The following is a description of a gene set: from publication Zhou Q, Brown J, Kanarek A, Rajagopal J, Melton DA (PMID 18754011) Transcription factors expressed in progenitors of endocrine pancreatic cells. Human Gene Set: ZHOU_PANCREATIC_ENDOCRINE_PROGENITOR studied in species Mus musculus One goal of regenerative medicine is to instructively convert adult cells into other cell types for tissue repair and regeneration. Although isolated examples of adult cell reprogramming are known, there is no general understanding of how to turn one cell type into another in a controlled manner. Here, using a strategy of re-expressing key developmental regulators in vivo, we identify a specific combination of three transcription factors (Ngn3 (also known as Neurog3) Pdx1 and Mafa) that reprograms differentiated pancreatic exocrine cells in adult mice into cells that closely resemble beta-cells. The induced beta-cells are indistinguishable from endogenous islet beta-cells in size, shape and ultrastructure. They express genes essential for beta-cell function and can ameliorate hyperglycaemia by remodelling local vasculature and secreting insulin. This study provides an example of cellular reprogramming using defined factors in an adult organ and suggests a general paradigm for directing cell reprogramming without reversion to a pluripotent stem cell state., and this is the list of marker genes: MYT1, NEUROD1, NEUROG3, PAX4, ISL1, NKX6-1, PAX6 (paired box 6), ARX, MLXIPL, NKX2-2, POU3F4, VDR, MAFB, MAFA